The following is a description of a gene set: Human Gene Set: GSE17721_LPS_VS_GARDIQUIMOD_4H_BMDC_UP mouse primary BMDCs were stimulated with tlr ligands and gene expression changes were profiled on Affymetrix arrays species: Homo sapiens from publication Amit I, Garber M, Chevrier N, Leite AP, Donner Y, Eisenhaure T, Guttman M, Grenier JK, Li W, Zuk O, Schubert LA, Birditt B, Shay T, Goren A, Zhang X, Smith Z, Deering R, McDonald RC, Cabili M, Bernstein BE, Rinn JL, Meissner A, Root DE, Hacohen N, Regev A (PMID 19729616) Genes up-regulated in comparison of dendritic cells (DC) stimulated with LPS (TLR4 agonist) at 4 h versus DC cells stimulated with Gardiquimod (TLR7 agonist) at 4 h., and this is the list of marker genes: TRA2B, OGFR, UBE2R2, TANC1, USP18, NTS, CAPN5, DTD1, FNDC3A, HDAC1, RTP4, GRIN1, ARHGAP6, EIF1AY, CNGA2, HPGD, SERTAD1, HLA-B, AP4B1, ADAR, RNPEP, TIMELESS, BLTP1, SDC4, CPT1A, POLR2G, MXI1, PCNX1, HSPB2, GCNT2, TCF4, JARID2, RBM7, MPP1, TOX4, CCDC59, RTCA, MTHFS, CLCF1, CKB, RHOB, NEDD9, ATP11B, VAPB, CENPE, MTARC2, VNN1, ACADSB, KCNMB1, CLDN15, COQ3, ORM1, SLC38A1 (solute carrier family 38 member 1), TNFRSF13C, TOR3A, RSL24D1, LATS1, BCL3, KLRK1, HELZ2, PLEKHF1, CAMLG, NUB1, ATRX, CRYBA1, HOXD8, PCMT1, NLGN2, ITPKA, REEP3, ABCB4 (NCBI Gene Id 5244), EBI3, AKT2, BCL2L1, CYSRT1, MAD2L1, GTPBP2, ELF1, CSF1, FKBP7, ATP6V1D, COX18, SFXN2, NECTIN2, RGS1, JDP2, ARHGAP17, OCIAD1, SMAGP, STX1B, HINFP, PLCL2, ETHE1 (ETHE1 persulfide dioxygenase), CCNJ, PDPN, RGS14, PPP2R2A, AXIN2, SEC24B, C3AR1, TMCO3, IQGAP3, SLC30A1, ZNF521, SEH1L, SLIRP, PARP8, FARSA, ITGAV, CDK20, STK39, TIMM17B, PPY, NAA15, SNX10, TNKS1BP1, ENTPD1, HMGN3 (high mobility group nucleosomal binding domain 3), PWP1, PFDN6, RAB12, PRPF31 (NCBI Gene Id 6106), CCL7, ATP13A1, KRTAP3-1, WASHC4, USP25, HOXB3, CLTRN, AQP2, RHOH, RDH11, PSMB9 (proteasome 20S subunit beta 9), AP2B1, PYCARD, RASA4, MTMR2, ZFP92, GADD45B, TMEM219, NKD2, CCL13, ZNF281, ADAM33, TMEM229B (NCBI Gene Id 161145), RCSD1, BMP15, NR3C1, PLAT, ENPP3, TEFM, IL36A, SERPINC1, GPSM2, TBL1X, FGF22, BZW2, SPTLC2, UBE2F, DLL4 (delta like canonical Notch ligand 4), GEMIN7, UBE2D1, PCDH7, KCNS1, PHF20L1, SLC15A2, ART3, DEXI, APOBEC3B, LARP1, MOV10 (NCBI Gene Id 57723), CRBN, BMX, DZIP1, SERPINE1, NAA20, DUSP2, IRF2, SAT1, SNW1, LOXL3, SHF, TRIO, ANKRD33B, KDR, NCK2, MED28, STXBP1, PCNA, TFAP2A, PHKG1, MYOD1, MDFIC, RBCK1, IRF7, RNF19A, HLA-E, SMU1, SLCO3A1, SH3KBP1